Given this list of marker genes Hmgb1, Ahr, Cand1, Psmc6, Thra, Wnt10b, Ikzf1, Trp53, Creb1, here is a description of the gene set: Mouse Gene Set: GOBP_REGULATION_OF_RNA_POLYMERASE_II_TRANSCRIPTION_PREINITIATION_COMPLEX_ASSEMBLY Any process that modulates the frequency, rate or extent of RNA polymerase II transcriptional preinitiation complex assembly. studied in species Mus musculus